Given this list of marker genes Umps, Acod1, Hoga1, Uxs1, Mlycd, Coq4, Shmt2, Park7, Fahd1, Tha1, Me2, Amd1, Acmsd, Hacl1, Ddc, Ggcx, Gadl1, Oaz1, Pck1, Echdc1, Oaz2, Clybl, Hdc, Pdxdc1, Sgpl1, Hmgcl, Mvd, Aldoa (aldolase A, fructose-bisphosphate), Pisd, Gad1, Hmgcll1, Oaz3, Azin2, Ddt, Npl, Gad2, Me1, Ldc1 (NCBI Gene Id 332942), Pck2, Dera, Shmt1, Ppcdc, Azin1, Paics, Aldoart2, Me3, Armt1, Odc1 (ornithine decarboxylase, structural 1), Urad, Tyw1 (NCBI Gene Id 212960), Got1, Aldob, Amd2, Aldoc, Mocs1, Csad, Urod, Aldoart1, here is a description of the gene set: Mouse Gene Set: GOMF_CARBON_CARBON_LYASE_ACTIVITY species: Mus musculus Catalysis of the cleavage of C-C bonds by other means than by hydrolysis or oxidation, or conversely adding a group to a double bond.